The following is a description of a gene set: Mouse Gene Set: GOBP_POSITIVE_REGULATION_OF_INTRINSIC_APOPTOTIC_SIGNALING_PATHWAY_BY_P53_CLASS_MEDIATOR Any process that activates or increases the frequency, rate or extent of intrinsic apoptotic signaling pathway by p53 class mediator. species: Mus musculus, and this is the list of marker genes: Rpl26, Knl1, Bmyc, Ubb, Trp73, Steap3, Sh3glb1, Rps7, Msx1 (msh homeobox 1), Myc